Given this list of marker genes DGKK, HOXB13, CEACAM1, PABPC4, NDP (NCBI Gene Id 4693), ODAM, GGCX, HRAS, ECRG4, KLKB1, DPYSL3 (NCBI Gene Id 54406), TNFAIP3, ACTG1, RAP2B, SERPIND1, TFPI2, ANGPTL1, BLOC1S4, DGKG, MYLK, DDIT3, MIR1298, THBD, STAT3, SAA1, C1QTNF1, EXTL3, ANGPTL6, SPP1, CHMP4C, EPHB2, PRCP, PF4, AJUBA, PDGFB, TAFA5, CCR1, ADGRG1 (NCBI Gene Id 9624), WNT3A, CASK, PLET1, MMP2, LRIG2, TSKU, NF1, MCAM, KREMEN1, EPO, CSRP1, ELK3, IL10, MIR221, MMP12, TNF, NRP1, ENTPD2, HSPB1, PPARD, IL6R (interleukin 6 receptor), PLEK, INS, TSPO, NMNAT1, PHLDB2, ALOX12, MAP2K7, HTN1 (histatin 1), MIR222, WNT5A, PRRG4, HRG, CCN4, MRTFA, FIBP (FGF1 intracellular binding protein), ISL1, ENG, SRF, F2RL1, SOD2, CLDN3, TEC, CHMP5, CX3CR1, SOD1, SERPINC1, VPS4A, PLG, CCR2, PLCG2, MYH10, EPB41L4B, PRSS56, ANGPT2, CD44, PLAU, TNC, ZFP36L2, PROZ, NEO1, SYT7, TLN1, FN1, F8, COL5A1, KANK1, SERPINF2, GNA13, PLAUR, SLC1A3, DRD5, UBASH3B, RAB3A, ANXA8, KLF4, SERPINB2, RAF1, INPP5F (inositol polyphosphate-5-phosphatase F), TOR1A, WNT7A, MIR200B, FAP, BCL2, MAP1B (microtubule associated protein 1B), DHFR, ALOX15, FGFR1OP2, PDGFA, CHMP4B, PLA2G4A, PLSCR1, CHMP2A, FOXF1, NMNAT3, HMOX1, SCARB1, DGKQ, TSPAN32, SERPINA1, GP5, SMPD1, ABHD2, ANGPTL2, NR3C1, PPIA, NDNF, PDPN, CAV1, RREB1, VAV2, MTR, RTN4RL2, FGF2, NRG1, MIR34A, PDGFRA, VASH1, AP3B1, CHMP3, ITGB1, RASA3, VEGFB, ITGB6, JUN, EPPK1, RGMA, ANXA2, PRKCE, IGF1, APOH, VPS33B, USF1, MAPK8IP3, RTCA, LNPK, IL6ST, NEFL, FGF1, NTRK1, PROS1, METAP1, GP1BA, PDCD10, FGL1, EREG, BRAF, SLC11A1, TLR4, SERPINE2, GATA4, S100A10, TMEM97, GAP43, MYOZ1, FGG, IL1RL1, GAS6, ITPK1, C6orf89, CERS2, PDIA3, HBB, STK24, TUBB1, SDC4, ITGAV, GPX1, TREM2, TPM1, BAX, DUOX2, CLIC1, LYN, ACTN1, LCK, DMTN, ADAMTS18, TGFB2, PTK7 (NCBI Gene Id 5754), VKORC1, FUT10, SLC1A1, PRRG3, DSG2, REG3A, MAP2K2, ZFP36L1, TLR3, GLI1, TMPRSS4, CASP3, APCS, PTN, SPRR3, ACVRL1, HTN3, TIMP1, PPP3CA, F13B, ADAMTS13, PTPRF, HBEGF, RTN4R, NFKBIZ, PRDX2, FERMT1, POU2F3, AJAP1, SRSF6, PRKCA, DGKI, F11, JAML, CHMP4A, LRG1, RTN4RL1, ITGB5, ADAM17, BNIP3, ITPR3, NPR2, CPB2, FGF10, SCUBE1, NFE2L2, GRHL3, PROC, SCRIB, RAB27A, P2RX4 (NCBI Gene Id 5025), YAP1, PAX6, SYK, CLASP1, MYL9, REG3G, DCBLD2, LAMB2, CTNNA1, MIR21, AURKA, NFIA, ADTRP, ALOX5, EVPL, NOL3, VCL, CRK (CRK proto-oncogene, adaptor protein), ADRA2C, DST, CHMP6, C4BPB, SERPINA10, RANGAP1, NLRP6, ITGA2, MPIG6B, BLOC1S3, DDR1, DSP, MIA3, FOLR1, PIK3CB, MAG, F12, PTPRS, HPS6, SARM1, GATA2, F5, SVEP1, GNAQ, TSPAN9, AXL, DTNBP1, ITGB3, PAFAH2, AQP1, ARFGEF1, KRT1, ERBB2, CD151, COL3A1, CNN2, EMILIN2 (elastin microfibril interfacer 2), NAGLU, F11R, GATA1, ITGB4, HIF1A, PROCR, MORN4, CD40LG, PIK3CA (NCBI Gene Id 5290), NPPC, PPARA, FKBP10, CCN2, PECAM1, VEGFA, P2RX1, FERMT2, AK3, DRD2, AHNAK, CAV3, HPS5, FOXC2, FGF7, CHMP4BP1, FZD6, PEAR1, F13A1, MAPK9, MTOR, PPARG, CARMIL2, PRKCD, MIR17, SHH, SLC4A1, NFIB, MYOF, ENTPD1, ILK, TMX1, P2RY12, SOX2, ARHGEF19, F2, PIK3CG, FOSL1, KNG1, INSL3, CORO1B, ARF4, JAK2 (Janus kinase 2), ANXA5, HPSE, ARHGAP24, APOA4, GKN2, NOS3, NOG, SELP, NOTCH2, ADRA2A (adrenoceptor alpha 2A), UCK2, CHMP2B, MIR15B, ANO5 (anoctamin 5), PTK2, FGA, VAV3, VTN, EMILIN1, CNTF, MFSD2B, WNT1, DGKB, MAP2K1, CD2AP, ITGA5, CHMP7, RAC1, TYRO3, TRIM72, GPR4, TMIGD3, FIGNL2, CD59, SLC6A4, HTR2A, HMGB1, CLASP2, FOXA2, ANGPTL7, CHMP1A, FGB, ANGPT4, EDN1, ZFP36, IL1A, MSX2, FCER1G, NACA (NCBI Gene Id 4666), SERPING1, CDKN1A, GRIN2A, CD109, F3 (coagulation factor III), DGKA, TGFBR1, F2RL2, GP1BB, FBLN1, EDNRA, CASP7, ARHGAP35, F2R, GP6, CD36, VAV1, VWF, COMT, FUNDC2, FLNA, KDR, TBXA2R, MIR29A, SYT11, F2RL3, CYP4F2, ANGPTL4 (angiopoietin like 4), SMOC2, LMAN1, DHFRP1, GNA12 (G protein subunit alpha 12), KRT6A, MAP2K4, F7, SH2B3, CD34, RIPOR1, MMRN1, CHMP1B, SLC7A11, FLRT3, PTPN6, SLC12A2, ACTB, PRKG1, GIPR, WFDC1, OCLN, DDR2, ST3GAL4, PRKCQ, MYL12A, SRC, PRRG1, PTPRJ, WDR83, TNR, CX3CL1, WAS, POU5F1, XBP1, C1GALT1C1, HNF4A, ADRA2B, IL6, IL33, C1orf54, CLDN4, VPS4B, KLK6, ADORA3, CLEC7A, SLC1A2, CYP4F11, BLOC1S6, FZD7, EXT1, VIL1, ADORA2A, CLDN1, PUM2, PLEC, MACF1, CTSG, ARL8B, MDK, TGFB1, LACRT, COL6A1, TREML1, PTEN, DUOX1, ERBB3, ADIPOR2, SFTA3, MATN2, GP9, LYVE1, ANGPT1, LCP1, CDK1, DGKD, GRIN2C, CD9, RHOA, FERMT3, PPL, STXBP3, ANO6, GNAS, MIR451A, MERTK, SIGLEC10, GRN, IL17A, ANXA1, PLAT, MIR431, STXBP1, P2RY1, DGKH, CELA2A, NREP, APOD, WNT4, VANGL2, MAPK14, CADM4, PDIA2, SULF2, EPHA4, F9, KCNB1, DAG1, INHBB, TSPAN8, PAK1, ENPP4, TYROBP, TFPI, SMAD3, KCNK2, B4GALT1, DGKE, GIT1, SCARF1, HPS4, CD40, KIAA0319, HGFAC, F10, MYH9, SERPINE1, RHOC, TNFRSF12A, APOE, DGKZ, COMP, AGER, NTRK3, TMEFF2, KLK8, PRRG2, SYTL4, JMJD1C, THBS1, INHBA, here is a description of the gene set: species: Homo sapiens Human Gene Set: GOBP_RESPONSE_TO_WOUNDING Any process that results in a change in state or activity of a cell or an organism (in terms of movement, secretion, enzyme production, gene expression, etc.) as a result of a stimulus indicating damage to the organism.